The following is a description of a gene set: species: Homo sapiens The gene expression program underlying the specification of human cell types is of fundamental interest. The study authors generated human cell atlases of gene expression and chromatin accessibility in fetal tissues. For gene expression, the study authors applied three-level combinatorial indexing to >110 samples representing 15 organs, ultimately profiling ~4 million single cells. The study authors leveraged the literature and other atlases to identify and annotate hundreds of cell types and subtypes, both within and across tissues. Our analyses focused on organ-specific specializations of broadly distributed cell types (such as blood, endothelial, and epithelial), sites of fetal erythropoiesis (which notably included the adrenal gland), and integration with mouse developmental atlases (such as conserved specification of blood cells). These data represent a rich resource for the exploration of in vivo human gene expression in diverse tissues and cell types. Human Gene Set: DESCARTES_FETAL_THYMUS_VASCULAR_ENDOTHELIAL_CELLS Marker genes curated from the annotated cluster as represented in the Descartes Human Gene Expression During Development database. from publication Cao J, O'Day DR, Pliner HA, Kingsley PD, Deng M, Daza RM, Zager MA, Aldinger KA, Blecher-Gonen R, Zhang F, Spielmann M, Palis J, Doherty D, Steemers FJ, Glass IA, Trapnell C, Shendure J (PMID 33184181), and this is the list of marker genes: EGF, HIF3A, PPFIBP1, ABLIM3, NECTIN2, MEOX2, EPHB4, LYVE1, AOC3, MPDZ, PODXL, CD36, SNTG2, DIPK2B, THSD7A (NCBI Gene Id 23249), RNF220, RHOJ, PDIA5, KANK3, EMCN, TGM2, IL7, NR2F2-AS1, ZNF521, RNF152, BCAM, PTPRB, MYO1B, UBTD1, EDEM2, CFAP161, NOVA2, FGD5, TIE1, DISC1FP1, PROX1, ARHGAP29, PTPN14, CAV1, RASIP1, NR3C2, NALF1, PRELID2, A2M, LINC00472, PCDH17, GASK1B, GJA4, RFTN2, VWF, TLL1, PALMD, INO80C, ANO2, MEG8, MMRN1, MYRIP, STOM, PREX2, SHE, ERG, PGM5, COL4A1, LRMDA, PPARG, FGD4, ID1, HOXB3, ST6GALNAC3 (NCBI Gene Id 256435), FLT1, STXBP6, NRN1, ADGRF5, CCL21, CALCRL (calcitonin receptor like receptor), MET, NRG3, ITGA6, SEMA3A, TFPI, RASGRP3, TNFRSF11A, KDR, RELN, NR2F1-AS1, CLDN5, ADCY4, EGFL7, ELK3, ADAMTS9, CHRM3, MCAM, LDB2, EPAS1, PLVAP, DOCK9, PKHD1L1, RADIL, ADGRL4, SHANK3, GNG12-AS1, TEK, TEFM, NFATC1, CAVIN2, ARAP3, MYCT1, CDK9, SCARF1 (NCBI Gene Id 8578), COL15A1, WWTR1 (NCBI Gene Id 25937), MECOM, ECSCR, RGS6, GLIS3, HMCN1, SCHIP1, MPP7, LINC02147, WASF3, APLNR, KALRN, DLGAP1, STAB2, PRCP, PCAT19, NUAK1, TACR1, ASNS, PRR5L, NALF1-IT1